The following is a description of a gene set: Human Gene Set: NABA_ECM_REGULATORS studied in species Homo sapiens from publication Naba A, Clauser KR, Hoersch S, Liu H, Carr SA, Hynes RO (PMID 22159717) Genes encoding enzymes and their regulators involved in the remodeling of the extracellular matrix One hallmark of ECM proteins is their domain-based structure. Exploiting this characteristic, we established a list of diagnostic InterPro domains commonly found in ECM proteins. We know that some of the domains used to select positively for ECM proteins are also found in transmembrane receptors and proteins involved in cell adhesion (growth factor receptors, integrins, etc) that do not belong to the ECM. These families of proteins also display a subset of specific domains and transmembrane domains incompatible with definition as “extracellular matrix” proteins. Therefore, a second step comprised a negative selection using another set of domains and a transmembrane domain prediction. Manual curation of the matrisome lists also allowed us to add a very few known ECM proteins that do not contain any known domains. Protein-centric predictions were then converted to gene-centric lists. Finally, knowledge-based annotation of these gene lists allowed us to define subcategories within the core matrisome; namely, ECM glycoproteins, collagens, and proteoglycans. We also defined separate lists of domains commonly found in 1) ECM-affiliated proteins (proteins that share either some architectural similarities with ECM proteins or that are known to be associated with ECM proteins; 2) ECM regulators: ECM-remodeling enzymes, crosslinkers, proteases, regulators etc.; 3) secreted factors, many of which are known to bind to ECM and others that may. As for the core matrisome list, we also defined lists of domains that excluded mis-assigned proteins from these categories. Using similar bioinformatic pipelines as for the core matrisome, we defined three categories of “matrisome-associated” proteins: ECM-affiliated proteins, ECM regulators, and secreted factors., and this is the list of marker genes: ADAM11, ADAMTS12, SERPINA9, MMP20, AMBP, ADAMTSL3, HYAL4, ADAM12, ADAM9, PLAU, CPAMD8, PLG, TIMP2, PAMR1, CST4, ADAMTS10, TIMP4, CTSD, SERPINA12, SERPINA5, TGM5, ITIH4, P4HA2, MMP14, PZP, MMP2, P3H3, CST2, ADAMTS1, TGM6, HYAL2, PLAT (NCBI Gene Id 5327), NGLY1, EGLN3, ADAM22, TGM4, ADAMTS3, PRSS12, TLL2, ITIH2, LOXL1 (lysyl oxidase like 1), OGFOD2, SERPINA4, CD109, CSTB, ADAMTS8, FAM20B (FAM20B glycosaminoglycan xylosylkinase), TGM1, SERPINB13, MMP12, SERPINB4, SERPINA7, MMP8, P4HTM, CTSV, ADAMTS16, CTSO, SERPINB11, SERPINA11, MMP25, MMP27, ADAMTSL5, P4HA3, ADAMTSL1, CST3, HTRA3 (NCBI Gene Id 94031), ADAM30, PRSS1, ADAMTS9, TMPRSS15, MMP19, SERPIND1, ADAMTS14, CSTL1, CTSZ, ADAMTS2, MMP13, PAPPA, SERPINB10, CTSB, HPSE2, ELANE, MMP16, HRG, CPN2, CTSW, A2M, ADAMDEC1, PLOD3, SERPINF1, TLL1, ADAMTS17, A2ML1, CST6, ITIH5, PRSS3, LOXL3, SERPINF2, F13A1, P3H2, SERPINB9, CST7, PAPPA2 (pappalysin 2), LOX, ITIH3, CTSG, HPSE, TIMP3, HABP2 (hyaluronan binding protein 2), P3H1, MMP9, PLOD2, CTSC, SERPINE3, MMP10, ADAM29, ADAMTS20, PI3, TGM7, ADAMTS19, CELA2B, SERPINB12, CSTA, ASTL, MASP1, MMP7, SERPINA1, CTSF, ADAM15, MEP1B, ADAMTS13, LOXL4, SERPINB5, F13B, P4HA1, AGT, PLOD1, ADAM18, SULF2, MMP15 (NCBI Gene Id 4324), ADAM23, EGLN1, MMP3, SERPINC1, CST5, SERPINB1, CTSK, HTRA4, ADAMTS6, ADAMTS7 (NCBI Gene Id 374629), F12, PCSK5, CTSS, SULF1, ADAM32, ADAMTS4, LOXL2, ITIH6, PCSK6, CELA2A, SERPINI1, MMP28, ADAMTSL4, F7, SERPINB2, HTRA1, KAZALD1, ST14, PRSS2 (NCBI Gene Id 93431), TGM3, SERPINB6, SERPINE1, ADAMTS18, SERPINI2, SERPINA10, HMSD, CST8, ITIH1, SERPINA3, MEP1A, SERPINB8, CTSH, C17orf58, SERPINB7, ADAMTS15, SERPINH1, HYAL1, CST9L, MMP11, KNG1, ADAM21, CTSA, ADAM8, CST1, FAM20C, F2, SERPINB3, MMP1, F9, SERPINE2, SERPINA2, CST9, CELA3B, ADAM33, SLPI, KY, BMP1, MMP26, ADAM20, ADAM7, ADAMTSL2, OGFOD1, SERPING1, SPAM1, TIMP1, LPA, CELA3A, ADAM10, CTSL, MMP21, FAM20A, F10, CELA1, HYAL3, ADAMTS5, CST11, MMP24, MASP2, CTSE, ADAM2, ADAM19, EGLN2, ADAM28, MMP17, TGM2, ADAM17, MMP23B, SERPINA6 (NCBI Gene Id 866)